The following is a description of a gene set: Mouse Gene Set: GOMF_FUCOSYLTRANSFERASE_ACTIVITY species: Mus musculus Catalysis of the transfer of a fucosyl group to an acceptor molecule, typically another carbohydrate or a lipid., and this is the list of marker genes: Fut4, Fut7, Fut10, Fut8, Fut9, Fut11, Fut2, Fut1, Sec1, Pofut1, Pofut2